The following is a description of a gene set: Human Gene Set: GOBP_REGULATION_OF_ANOIKIS studied in species Homo sapiens Any process that modulates the frequency, rate or extent of anoikis., and this is the list of marker genes: CAV1, BRMS1, CRYBA1, SNAI2, MCL1, ZNF304 (NCBI Gene Id 57343, zinc finger protein 304), MYBBP1A, ANKRD13C, ITGA5, BCL2L1, PIK3CA, PTK2, CEACAM5, SRC, TLE1, NOTCH1 (notch receptor 1), PTRH2, SIK1 (salt inducible kinase 1), NTRK2, PIK3R3, ITGB1, BCL2, CEACAM6, TLE5, CHEK2, PDK4